The following is a description of a gene set: Mouse Gene Set: REACTOME_CD28_DEPENDENT_PI3K_AKT_SIGNALING species: Mus musculus CD28 dependent PI3K/Akt signaling, and this is the list of marker genes: Pik3cb (phosphatidylinositol-4,5-bisphosphate 3-kinase catalytic subunit beta), Them4, Pik3r3, Lck, Rictor, Fyn, Akt3, Cd80, Cd28, Pik3r1, Akt2, Pik3r6 (NCBI Gene Id 432574), Pik3r5, Pdpk1, Mapkap1, Pik3r2 (NCBI Gene Id 18709), Mtor, Pik3cd, Pik3ca, Akt1, Map3k14, Pik3cg, Map3k8, Mlst8, Prr5, Trib3, Cd86